The following is a description of a gene set: Expression microarray analysis identified over genes regulated during puberty in the mouse mammary gland. Most prominent were genes whose expression increased in parallel with pubertal development and remained high thereafter. Members of the Wnt, transforming growth factor-beta and oestrogen-signalling pathways were significantly overrepresented. Comparison to expression data from CITED1 knockout mice identified a subset of oestrogen-responsive genes displaying altered expression in the absence of CITED1. Included in this subset are stanniocalcin2 (Stc2) and amphiregulin (Areg). Chromatin immunoprecipitation revealed that ERalpha binds to oestrogen response elements in both the Stc2 and Areg genes in the mammary gland during puberty. Additionally, CITED1 and ERalpha localize to the same epithelial cells of the pubertal mammary gland, supporting a role for interaction of these two proteins during normal development. In a human breast cancer data set, expression of Stc2, Areg and CITED1 parallel that of ERalpha. Similar to ERalpha, CITED1 expression correlates with good outcome in breast cancer, implying that potential maintenance of the ERalpha-CITED1 co-regulated signalling pathway in breast tumours can indicate good prognosis. from publication McBryan J, Howlin J, Kenny PA, Shioda T, Martin F (PMID 17486082) Genes up-regulated during pubertal mammary gland development between weeks 3 and 4. Human Gene Set: MCBRYAN_PUBERTAL_BREAST_3_4WK_UP species: Mus musculus, and this is the list of marker genes: SLC25A35, SLC39A8, TJP2, HAS2, FN1, MKRN1, SRPX2, ELF5, IRX3, HAL, GJA1 (NCBI Gene Id 7953), MRC2, PTN, TGFB3, ATP1A3, CLDN3, CUX1, MFGE8, PRKACB, RNASE3, PTPN5, TMEM51, CLU, ST14, PLK2, SNORC, TMEM79, LALBA, PRKCE, APOC2, ATP8A1, ATP6V0A1, MYB, ACACA, CDH5, TNFRSF12A, GM2A, PHLDA1, UNC119, CABLES1, FSCN1, IRX2 (NCBI Gene Id 93965), SOX13, EHF, GRHL1, RUNX1, WFDC2, ETS2, DBP, CXCL14, ESRP1, CLDN10, SPP1, BASP1, CITED1, CDK1 (NCBI Gene Id 983), FXYD3, GABARAPL1, ACLY, EFEMP1, EDNRA, MMP14, GSN, CDCP1, CD55, SERPINA1, SCD, TEAD2, KIT, CSN1S1, LY6D, IGHA2, GATA3, PTPN14 (NCBI Gene Id 5784), FBXO32, CYP2D6, TMEM109, C2CD2L, SLC2A5, EPCAM, RNF149 (ring finger protein 149), CD248, COL9A1, GALC, CEMIP2, MYH11, RASSF2, MUC15, TFAP2C, DNAJC12, LRRK1, SHROOM3, LGALS3, PLET1, CEACAM1, HLA-DRB1, FGF13, CSN3, FGG (NCBI Gene Id 2266), GABRP, CNN1, CDH1, LCN2, HK1, TFCP2L1 (transcription factor CP2 like 1), CLCA3P, COPS2, SOCS6, LRATD1, ABCC3, ACSF2, PGAP2, SOX9, FAM241B, BTN1A1, CYB5R3, BLTP3A, RASSF3, FOXA1, PRPF19, SGTB, EPDR1, MAPK8IP1, HSD11B1, OGT, STC2, DNM1, LRP5, TIE1, MTARC1 (mitochondrial amidoxime reducing component 1), NFE2L3, AQP5, CSPG4, GYS2, KRT8, CARHSP1, SLC12A2, GADD45A, IGFBP2, PERP, BMP1, DSP, COL8A1, DLAT, GAS1, HSPB8, HDAC11, KRT18, COL16A1, BEX3, MAFB, KRT19, RAB27B, KRT14, TMPRSS2, CDKN2B, RAD51AP1, FADS2, C1orf210, WWC1, P2RX5, SDC1, ELOVL6, TACSTD2, JCHAIN, TLCD4, ITFG1, KRT7, TNC, EGR2, SC5D, IRF6, LTF, INHBB, ATP6V1B1, HACD4, SIAH2, TSPAN8, ANKH, TMEM268 (transmembrane protein 268), TMEM45B, PADI2, SFRP1, PDK1, ADISSP, LIMA1, MLPH, SLC15A2, PROM2, HSPA1B, COMT, ALDOC, ANO1, KCNB1, NHSL3, TGIF1, TRPS1, LIPG, SLC38A10, CCN1, ADGRD1 (adhesion G protein-coupled receptor D1), GMPR, SPRR1A, GAB1, MTCH2, CHI3L1, PI16, ID4, FZD1, SLC25A24, PEAR1, ADM